Given this list of marker genes TCTN3, CYP4V2, PEX14, B9D2, TMEM67, MPDZ, AKT1, VPS13B, WT1, UBE3B, SHH (NCBI Gene Id 6469), GRHL2, BEST1, NDE1, PRPH2, TSC1, TXNDC15, OAT, TIMP3, MICOS13, NDP, POMGNT2, ZNF408, ACTB, TMEM107, LRP5, NDUFB11, CHN1, BCOR, SIM1, TCTN2, CC2D2A, PEX6, CFH, CFI, PEX13, MKS1, PAX6, PEX2, TUBGCP4, ACVRL1, DACT1, ZNF423, CEP290, TCTN1, HADHA, LARGE1, FAS, MAFB, HMGB3, TEAD1, TBX22, PAX2, SALL1 (spalt like transcription factor 1), PEX11B, HLA-A, TMEM216, RXYLT1, SLC25A15, ZEB2, RERE, CTNNB1, NAA10, EFEMP1, VSX1, PEX3, PEX26, YAP1 (NCBI Gene Id 10413), CRPPA, PIGL, MAX, COX7B, SEMA3E, PEX12, EYS, CRX, POMK, HLA-DRB1, POU3F4, COL18A1, PTPN22, SPTBN1, CLDN19, PEX19, B3GALNT2, TMEM237 (transmembrane protein 237), PEX10 (NCBI Gene Id 5192), TSPAN12, TMEM231, HCCS, B9D1, COL4A1, CHD7, VPS33A, C1QTNF5 (NCBI Gene Id 26141), DCT, VPS35L, PORCN, CRB1, LCA5, POMT2, KRAS, B4GAT1, ROM1, RBP4 (retinol binding protein 4), MAGEL2, ZEB1, RPGRIP1L, INPP5E, HMX1, C12orf57, IFNG (NCBI Gene Id 3458), COL9A1, PEX16, PNPLA6, DPP6, SAG, GUCA1A, RPGRIP1 (RPGR interacting protein 1), SIX3, TSC2, JAG1 (NCBI Gene Id 3715), DPYSL5, RNU7-1, ADAMTS18, IKBKG, FKRP, CLCN2, KIF11, PEX5, DHX16, VCAN (versican), ABCB6, TUBGCP6, RPE65, HHAT, CCDC22, COL8A2, FSCN2 (NCBI Gene Id 25794), FZD4, RP2, CDH3, FZD5, OVOL2, OCRL, SALL4, PEX1, CSPP1, NRL, GUCY2D, ZNF668 (zinc finger protein 668), LRAT, GZF1, POMT1, FKTN, SIX6, SPATA7, WAC, GDF3, TMEM138, CHM, WASHC5, DAG1, POMGNT1, BMP4, here is a description of the gene set: An abnormality of the choroid and retina. Abnormal chorioretinal morphology species: Homo sapiens Human Gene Set: HP_ABNORMAL_CHORIORETINAL_MORPHOLOGY